Given this list of marker genes NOD2, MIR138-1, SASH1, GPS2, PLAA, CEP63, RIPK2, UBE2N, BIRC2, PTPN22 (protein tyrosine phosphatase non-receptor type 22), UBE2V2, PARP10, DDX3X, UBE2V1, here is a description of the gene set: Any process that modulates the frequency, rate or extent of protein K63-linked ubiquitination. Human Gene Set: GOBP_REGULATION_OF_PROTEIN_K63_LINKED_UBIQUITINATION studied in species Homo sapiens